The following is a description of a gene set: species: Homo sapiens Human Gene Set: GGCNRNWCTTYS_UNKNOWN Comprehensive identification of all functional elements encoded in the human genome is a fundamental need in biomedical research. Here, we present a comparative analysis of the human, mouse, rat and dog genomes to create a systematic catalogue of common regulatory motifs in promoters and 3' untranslated regions (3' UTRs). The promoter analysis yields 174 candidate motifs, including most previously known transcription-factor binding sites and 105 new motifs. The 3'-UTR analysis yields 106 motifs likely to be involved in post-transcriptional regulation. Nearly one-half are associated with microRNAs (miRNAs), leading to the discovery of many new miRNA genes and their likely target genes. Our results suggest that previous estimates of the number of human miRNA genes were low, and that miRNAs regulate at least 20% of human genes. The overall results provide a systematic view of gene regulation in the human, which will be refined as additional mammalian genomes become available. from publication Xie X, Lu J, Kulbokas EJ, Golub TR, Mootha V, Lindblad-Toh K, Lander ES, Kellis M (PMID 15735639) Genes having at least one occurrence of the highly conserved motif M118 GGCNRNWCTTYS in the regions spanning 4 kb centered on their transcription starting sites. The motif does not match any known transcription factor binding site., and this is the list of marker genes: OSR1, ZC3H10, USH1C, FAM227B, C1orf131, LCOR, RNF13, GABARAPL2, ENOX1 (ecto-NOX disulfide-thiol exchanger 1), DNAJA2, UBXN6, SUN2, TBC1D22A, RPL41, ARFIP2, PCYT1A, SND1, TSC22D4, TIMM10B, CELF1, SMAP2, ZBTB3, XYLT2, NDUFS4, CLC, TBC1D17, SLC39A13, DHX30, GBA2, ATP6V1E1, RSKR, DACT3, PIGN, TERB1, ANKH, DNAJA1, GNPAT, HCCS, FGFR3, NKAIN1, CBLB, RPS6KA3, ISG20 (interferon stimulated exonuclease gene 20), TUG1, NEDD1, NREP, KRT14, IFI27L1, RPL18A, QPCTL, IRF2BPL, LIN54, KANSL1, LYVE1, RNF168, SRP14, SNRPD2, NOP53, SMAD6, RPE (NCBI Gene Id 96188), ADSL, RAB8A, RBM24, HOXA9, VSTM2L, ARFGAP1, SP2 (Sp2 transcription factor), CANX, KDM6A, NR3C2, DTWD1 (DTW domain containing 1), AKT1S1, PAFAH1B2, TMUB2, KLF10, AQP3, ELMO1, PATZ1, USP9X, EIF3L, PIP4K2B, EIF4A1, DDX24, ZBTB45, MAPK8IP3